The following is a description of a gene set: A cellular component consisting of one leaflet of a membrane bilayer and any proteins embedded or anchored in it or attached to its surface. Mouse Gene Set: GOCC_SIDE_OF_MEMBRANE studied in species Mus musculus, and this is the list of marker genes: Rgmb, Lypd6, Racgap1, Psg26, Ly6f, Stab2, Ceacam12, H2-M10.5, Nrn1, Anpep, Ap2m1, Efna4, Efna3, Gpc3, Clec4a4, Gp2, Lypd8, Muc17, Ano1, Itga10, Gnb2, Cr1l, Cd79a, Btn2a2, Skint5, Thbd, Gnrh1, Ccr4, H2-Ab1, Dlk1, Esyt3, Lrrc24, Slc1a1, Xcr1, Kcnab1, Cd209a, H2-T5, H2-M10.2, Canx, P2rx7, Clptm1, Sell, Cxcr5, Fgfr3, Gngt2, Ceacam3, Csf2rb, Fgb, Borcs8, Il5ra, Ccr1l1, Alg2 (ALG2 alpha-1,3/1,6-mannosyltransferase), Tirap, Atp1b2, Ap2a2, Cd207, Tlr4, Htr2c (5-hydroxytryptamine (serotonin) receptor 2C), Gfra2, Ece1, Bmpr1a, Itln1, Otoa, Epn3, Capn2, Skint7, Art2b, Dsg1b, Cd8b1, Azgp1, Cd200r1, Cd22, Ctsb, H2-Q2, Gypa, Traf3, Gng12, Ppp1r9b, Trpm8, Nphs2, Cxcr3, Tfr2, Clec4f, Itgav, Gngt1, Ntng1, Jup, Itgb6, Rasal3 (NCBI Gene Id 320484), Ly6g6d, Cd83, P2rx1, Tmem123, Lrp2, Il11ra1, Itga11, Micall1, H2-T15, Cxcr4, Gpc4, Ntm, Fcrl5, Rpl27, Fcrl6, Ackr4, Csf2rb2 (colony stimulating factor 2 receptor, beta 2, low-affinity (granulocyte-macrophage)), Hjv, Gfap, Snx18, Itgb2, Fcmr, Ifng, Cd34 (CD34 antigen), Iqgap1, Clec14a, C2cd2l, Asgr1, Lag3, H2-Ea, Gnaz, Vtcn1, Izumo1r, S100a6, Cd200r3, Birc2, Insr, Scube1, Gng13, Pgm5, Noa1, Lgals3, Dsg1a, Art3, Agap2, Mmp25, G6pd2, Psg21, Ncam1, H2-T13, Il4ra, 6030468B19Rik, Psg25, Jak1, Art4, G6pdx, Cd55, Pirb, Nt5e, Shroom4, Atp2a2, Cd44, Ackr3, Gnb3, Traf2, Drd4, Gnal, Cdip1, Gas1, Prss43, Adgre1, Kcnab2, Ldlrap1, Prss30, Rgs1, Lypd1, Cyld, Prss55, Enox1, Mcf2l, Esyt2, Cd79b, Gm4787, H60b, Ccl21b, Cdh13, Cd59a (CD59a antigen), Gnb5 (NCBI Gene Id 14697), Cfh, Mill1, Lilrb4a, Cd5, Itgax, Umodl1, Psg16, Ly6g5b, Chmp4b, Ceacam11, Mfge8, Sele, Cd69, Ndufaf5, Ly9, Gng4, Fcrlb, Rps28, Tnfrsf13b, Epor, Ceacam15, Fermt2, Trgv2, Diablo, Glrb, Gna15, Gfra3, Ccrl2, Btnl9, Ms4a1, Alpl, Ccr10, Pten, Becn1, Plet1, Cd160, Alg1, Smpdl3b (NCBI Gene Id 68772), Cd1d1, Ada, Gnb4, Gng8, Lct, Cx3cr1, Abcb1b, Tnfrsf11a (NCBI Gene Id 21934), Enpep (glutamyl aminopeptidase), Il2rg, Map2k2, Cdh5, Ldlr, Ighm, Mr1 (NCBI Gene Id 15064), Ncam2, Clec4n (NCBI Gene Id 56620), Dtna, Stac2, Gng2, Gng11, Gfra4, Flot1, Gnat1, Gria1, Tecta, Btnl1, Fkbp1a, Fcer1a, Tnfrsf14, Ermap, Mdga2, Gfra1, Btnl10, Pecam1, Cisd1, Alcam, Atp2b1, Cd19, Klre1, Gna14, Mtss2, Kit, Thbs1, Klrd1, Cd24a, Ly6i, Xpnpep2, Clec4d, Tnfsf13, Atp6ap2, Sema7a, Gp1ba, Kcnma1, Raet1e, Epb41, Cd3g, Myd88, Ap2s1, Lypd3, Prlr, Clec7a, Ache, Plaur (NCBI Gene Id 18793), H2-T23, Cntn4, Btnl6, Plppr4, Ptp4a1, Gnat3, Gng7, Dpep1, Ptpn7, Cd244a, Negr1, Mmp17, Plg, Aspscr1, Trgc4, Cxcr2, Cd209g, Hyal5, Gpihbp1, Alg13, Akp3, Selp, Gng10, Adam26a (NCBI Gene Id 13525), Mien1, Vwf, Klra1, Icam1, Epha5, Spam1, Cd274, Ctsk, Samd10, Alpi, P2ry12, Mill2, Cd209b, Ryr3, Abcg2, Fcer1g, Fgf8, Chrnb2, Bloc1s1, Lypd4, Hid1, Mgl2 (macrophage galactose N-acetyl-galactosamine specific lectin 2), Cd209c, Itga5, Cxcr6 (C-X-C motif chemokine receptor 6), Cd36, B4galt1 (UDP-Gal:betaGlcNAc beta 1,4- galactosyltransferase, polypeptide 1), Pkd2, Dnaja3, Lifr, Gpc6, Dnai2, Cfp, Lepr, Trpv1, Ap4b1, Trdc, Efna2, Flt3l, Muc16, Astn1, Th, Nucb1, Rgs8, Cd3d, Iqce, Alox15, Ptpn22, Antxr2, Bloc1s2, Gng5c, Chrna4, H2-Eb1, Rnf31, Pdcd1, Samd12, Loricrin, Chrna7, Trgc1, Tgm3 (transglutaminase 3, E polypeptide), Cabp1, Skint4, Icosl (icos ligand), Fcgr3, Cd2, Bst2, Itga7, Psg23, Cd40lg, Kcnj5, Itga2, Clec2f, Fcrla, Enpp6, Klra7, Pdcd1lg2, Btnl4 (butyrophilin-like 4), Il2rb, Calr, Fes, Lsamp, Abca1, H2-Aa, Fasl, Cntfr, Cntn2, Dpep3, Ighd, Adam4, Jak3, Hyal2, Gna12, Clec2e, Rgs2, Rorc, Borcs6, Clec2g, Cd59b, H2-K1, Gnat2, Clec2h, Il11ra2, H2-M9, Cdk16 (NCBI Gene Id 18555), Adam21, H2-M10.1, Lrp1, Klrb1b, Rps26, Gnb1, Cd48 (CD48 antigen), Neu3, Vnn3, Itga3, Skint11, Gucy2g, Dmd, Serpina5, Sppl2a, Ly6d, Syap1, Nlrp10, Alppl2 (NCBI Gene Id 96869), H2-M3, Itgad, H2-M10.4, Mpl, H2-T3, Rtn4rl2, Adam9, Adam26b, Ide, H2-M1, Sprn, Prn, Adam1b, Ppp3ca, Tnf, Arsa, Gng5, Fcrl2, Klrc1 (NCBI Gene Id 16641), Hfe, Anxa5, Eng, Ncf1, Clec4a2, Ccr3, Cdh1, Kcnq1, Cd200r2, Itgb1, Ly6e, Il7r, Adam1a, Clec12b, Iglc1, Aqp4, Gnao1, Il1rl1, Ulbp1, Litafd, Aqp2, Cd9, Chmp7, H2-M10.6, Vcam1, Prss8, Rasa3, Ly75, Gsr, Slc4a1 (solute carrier family 4 (anion exchanger), member 1), Scnn1b, Cd14, Ptpn4, Cd209d, Tgfbr2, Ly6l, H2-T24, Scnn1a, Skint1, Tnfrsf18, Ighg1, Trgv1, Skint3, Ly6h, Fga, Meltf, Qtrt1, Clec4g, Ambp, Myh9, P4hb, Ace, Bdh1, Asgr2, Slamf6, S1pr1 (NCBI Gene Id 99736), Itga4, Ap2b1, Socs3, Klra4, Snx5, Ccr7, Glra1, Skint2, Prmt8, Psg19 (NCBI Gene Id 26439), Rhoa, Adam25, Qtrt2, Pkp4, H13, Cxcl10, Adgre5, H2-M11, Borcs5 (NCBI Gene Id 67774), Itgae, Farp1, Tcn2 (transcobalamin 2), Spn, Il17a, Adam39, Tectb, Ceacam5, Efna1, Itpr3, Il13, Cd52, Clec4b2, Rasgrp4, Prnp, Mdga1, Spta1 (spectrin alpha, erythrocytic 1), Dag1, Msln, Ceacam1, Treh, Klrk1, Epm2aip1, Lrrk2, Gpc5, Cd209f, H2-T22 (NCBI Gene Id 15051), Itga2b, Siglece, Fcer2a, Prss42, Syt6, Prnd, Tnfrsf13c, Gpc1, Adam19, Cripto, Htra2 (NCBI Gene Id 64704), Il31ra (NCBI Gene Id 218624), Il6st, Osbpl2, Grk2, Clcn3, Stac, Scart2, Cnr2, Lamp1, Rab5a, Akap5, Enpp3, Ccr5, Rgma, Adam29, Tnfrsf4, St14, Gnai1, Vsir, Rtn4rl1, Slc2a4, Gna13, Mtss1, Hck, Itgam, H2-M5, Il9r, Gnas, Apoe, Itga8, Osmr, Raet1d (retinoic acid early transcript delta), Klrb1c, Kcnj3, H2-Q10, Fgg, Rtn4r, Cd209e, Cntn3, Adam24, Adam20, Prss41, Psg28, Enox2, Cd1d2, Slamf9, Pdpn, Rtbdn, Ghr, Gng3, Mcam (NCBI Gene Id 84004), Borcs7, Igsf21, Trgv3, Cd33, Ms4a2, Cxcl9, Frmd6, Alg14, Ly6c2, Cd80, Clec10a, Cfc1, Krt18, Kras, Slamf1, Adam30, Litaf, Gnai3, Gphn, Omg, Fer, Spaca4, Ryr2, Cd8a, Myzap, Umod, Ccr2, Ly6c1, Cd163, Gnai2, Mapt, Cxcl12, Ly6g, Gem (GTP binding protein overexpressed in skeletal muscle), Kcnip1, Cr2, Folr1, Ccr6, Ank2, Il6, Il23r, Tas2r118, Btla, Tnfrsf22, Atp2c2, Klri2, Ccr9, Coa8, H2-D1, Clec4a3, Art2a, Rs1, Thy1, Psg17, Clec4e, Il13ra1, Chmp4c, Ajap1, Folr2, Slc38a1 (NCBI Gene Id 105958), Nlgn1, Tfrc, Ly6k, Dpep2, Kxd1, Cd109, Il1r1, Kdr, Crlf1, Art1, Spa17, Flt3, H2-Q1, Ntng2, Ngfr, Gng14, Skint8, Ly6g5c, Ly6a, Alg5, Tmc1, Rab21, Il12rb2, Fcgr2b, Tlr2, Gnaq, Fcgrt, Psca, Efcab7, Il2ra, Traf6, Clec4b1, Sppl2c, Npcd, Adam34l, Slc7a5, Bst1, Cd4, Itga9, H2-M10.3, Btnl2, Cd28, Klrc2, Skint6, Dsg1c, Sppl2b, Tgfbr3, Prss21, Cd86, Cntn1, H2-Eb2, Crlf2, F2, Map3k5, Mmp19, Ceacam23, L1cam, Itgal, Scnn1g, Ptprc, Clec4a1, Adam6a, Lypd2, Icos, Itga1, Trgv5, Pakap, Gpc2, Entpd1, Tex101, Sdc1, Clec2i, Slc4a3, Ceacam13, Ccl19, Sppl3, Ccr8 (NCBI Gene Id 12776), Msn, Ackr2, Rnpep (NCBI Gene Id 215615), Trgc2, Nrn1l, Cd200r4, Il12rb1, Amot, Traf5, H2-Q6, Ly6g6c, Ctsl, Ikbkb, Ntsr1, Adam34, H2-Q7 (NCBI Gene Id 15018), H60c, Ptpn1, Cntn5, Itga6, Reck, Adgra3, Il4, Acp1, Csf3r, Cd226, Dnajc19, Snapin, Plau, Skint10, Myh10, Cd276, Adam6b, Heg1, Ank1, Cd248 (CD248 antigen, endosialin), Klrc3, Cd74, Plekha4, Mog, Vpreb1a, Fas, Musk, Lypd6b, Chuk, Ptpn3, Cd3e, Skint9 (NCBI Gene Id 329918), Epm2a, Ap2a1, Abcc4, Lyn, Gm2a, Ryr1, Dst, B2m, Vnn1, Fcgr1, Antxr1, Cd40, Cntn6, Car4, Gna11, Slamf7, Rps29, Otulinl, Pdgfra (NCBI Gene Id 231312), Cd27, Stac3, Tnfrsf9, Psg27 (pregnancy-specific beta-1-glycoprotein 27), Btnl12, Abcg1, Btn1a1, Lynx1, Cxcr1, Tnfrsf23 (tumor necrosis factor receptor superfamily, member 23), 2410137M14Rik, Robo4, Cd84, Gfral, Clec2d (NCBI Gene Id 93694), H2-M2, Dlg1, Efna5 (NCBI Gene Id 13640), Lypd5, Jak2, Il21r, Klri1, Fcgr4, H2-Q4, Itgb3, Ceacam14, Cyth1, Tlr8, Cpm, Ctla4, Il6ra, Il13ra2 (NCBI Gene Id 16165), Ccr1